Given this list of marker genes ADAMTS16, GREB1L, SOX8, NOTCH1, SIRT6, TACSTD2, FKBPL, HS3ST3A1, DCHS1, HNF1B, SIX4, PLXND1, WNT2, TBX2, MYC, CTNNB1, YAP1, COL4A1, SPRY2, WT1, WNT5A, DDR1, DLL4, HMGA2, TBX20, WNT6, SRC, GLI3, TCF21, VEGFA, ESR1, ETV5, RBM15, CTSH, EGF, PPP3R1, LEF1 (lymphoid enhancer binding factor 1), SRF, MYCN, TFAP2C, MAGED1, PAX8, GDNF, GPC3, PPP1CA, FGF8, LRP5, LGR4, CCL11, CTSZ, PAK1, IGF1, CSMD1, EYA1, WNT9B, PKHD1, TGFB1, TBX3 (NCBI Gene Id 91834), VDR, BMP2, SHH, KRAS, TIE1, GNA13, FGF1, BCL2, ILK, SEMA3E, SPRY1, LAMA5, SMAD4, BMP4, EDN1, FGFR2, PKD2, MDK (NCBI Gene Id 4192), WNT2B, GBX2, CAV3 (NCBI Gene Id 859), SIX1, GDF2 (NCBI Gene Id 51423), LAMA1, DAG1, VANGL2, CASR, MET, PAX2, RASIP1, GZF1, MSX2, PKD1, CITED1, BMP7, TMEM59L, SFRP2, GDF7, HOXD11, WNT1, MED1, FOXA1, PHB2 (NCBI Gene Id 11331), AGT, RDH10, SMO, SALL1, AGTR2, MIR16-1, GLI2, EPHA2, HOXA5, MMP14, NKX3-1, NOG, SOX9, NRP1, HS3ST3B1, CTNND1, ACVR1, MIR15B, ESRP2, DLG1, PTCH1, KDR, DLG5, PBX1, IHH, HHIP, NRARP, EDNRA, AR, ENG, MKS1, NKX2-1, PML, GREM1, NFATC4, CSF1, FOXC2, PGR, NPNT, TNF, KDM5B, NOTCH4, TNC, FGF10, STK4, CTNNBIP1, LHX1, AREG, TIMELESS, FOXF1, HOXB7, BTRC, WNT4, TGFBR2, FOXD1, SIX2, ABL1, SLIT2, PITX2, FGF2, CLIC4, EXT1, CELSR1, RSPO2, HOXA11, here is a description of the gene set: The process in which the anatomical structures of branches in an epithelial tube are generated and organized. A tube is a long hollow cylinder. Human Gene Set: GOBP_BRANCHING_MORPHOGENESIS_OF_AN_EPITHELIAL_TUBE species: Homo sapiens